Given this list of marker genes Tmem216, Ush1g, Cdkl1, Iqcb1, Spata7, Rpgrip1l, Wdr19, Adgrv1, Tmem67, Ush2a, Ift88, Sptbn5 (NCBI Gene Id 640524), Ttc8, Ift140, Intu, Septin2, Alpk1, Cc2d2b, Tmem231, D630045J12Rik, Rp1l1 (NCBI Gene Id 613256), Mks1, Poc5 (NCBI Gene Id 67463), Lca5, Ift122, Cfap36 (NCBI Gene Id 66744), Cetn2, Whrn, Cep131, Ttbk2 (tau tubulin kinase 2), Nek4, Kctd10, Kifap3, Ift57 (NCBI Gene Id 73916), Cetn1, Tmem237, Bbs4, Tctn1, Cibar2, Nphp1, Tsga10ip, Tbcc, Cplane1, Ift52, Tmem80, Kif3a, Cibar1 (NCBI Gene Id 68099), Traf3ip1, Rpgrip1, Mak, Tctn2, Dync2li1, Cc2d2a, Cfap410, Cep290, Pcdhb16, Cplane2, Macir, Rp1, Unc119b, Pcdhb22, Ift20, Tmem17, B9d2, Fam161a, Topors, Cetn3, Gnat1, Cfap53, Rpgr, Ccsap (NCBI Gene Id 73420), Bbs9, B9d1, Myo7a, Pcm1, Ahi1 (NCBI Gene Id 67502), Tmem107, Nphp4 (NCBI Gene Id 75293), Kif17, Arl3, here is a description of the gene set: species: Mus musculus Mouse Gene Set: GOCC_CILIARY_TRANSITION_ZONE A region of the cilium between the basal body and proximal segment that is characterized by Y-shaped assemblages that connect axonemal microtubules to the ciliary membrane. The ciliary transition zone appears to function as a gate that controls ciliary membrane composition and separates the cytosol from the ciliary plasm.